Given this list of marker genes REST, DIS3L2, TRIP13, GPC3, POU6F2, SRCAP, H19, BRCA2, WT1, AKT1, TRIM28, PTEN, here is a description of the gene set: A varicocele is a widening of the veins along the spermatic cord, leading to enlarged, twisted veins in the scrotum, and manifested clinically by a painless testicle lump, scrotal swelling, or bulge in the scrotum. Human Gene Set: HP_VARICOCELE Varicocele species: Homo sapiens